The following is a description of a gene set: An unpleasant sensation characterized by physical discomfort (such as pricking, throbbing, or aching) localized to the back. Human Gene Set: HP_BACK_PAIN studied in species Homo sapiens Back pain, and this is the list of marker genes: TMEM43, AEBP1, CLCN7, AKT1, HLA-B, BAP1, LMX1B, MESP2, CCND1, PPOX, TRAF7, WRN, SPAST, SMARCB1, SMARCE1, HGD, HMBS, MATN3, EMD, FLNC, SUFU, HELLPAR, FLI1, RASA1, COL2A1, CDKN2A, NKX3-2, HTRA1, CPOX, TERT, FHL1, PDGFB, SMAD4, BRCA1, SLC22A12, SYNE2, VHL, ABCD1, BRCA2, CAPN3, VCP, TP53, PALB2, TBX6, SMO, STAT6 (NCBI Gene Id 6778), VANGL1, PALLD, PIK3CA, SEC63, KRAS, ALDH18A1, LRP5, TCIRG1, RABL3, MEFV, LMNA, TRAPPC2, SYNE1, WASHC5, NGF, PLEKHM1, CFI, NAB2, PRKCSH, CD46, NF2, ATP7B, SLC2A9, SPTBN1, ANXA11, CFH, DLL3, POLR3GL, MNX1, TBX18